The following is a description of a gene set: Genes up-regulated in BCL6 low follicular helper T cells versus T conv cells. Human Gene Set: GSE24574_BCL6_LOW_TFH_VS_TCONV_CD4_TCELL_UP from publication Kitano M, Moriyama S, Ando Y, Hikida M, Mori Y, Kurosaki T, Okada T (PMID 21636294) We found that a number of Tfh cells downmodulated BCL6 protein after their development, and we sought to compare the gene expression between BCL6-hi Tfh cells and BCL6-low Tfh cells. species: Homo sapiens, and this is the list of marker genes: USP9Y, SPPL2B, PDHA2, BNIP1, ZNF200, CASP2, WNT11, OTUD3, TOR1B, PER1, PAX4, TBPL1, SGSM3, KCNF1, SUMO4, KALRN, VTN, AGT, SOCS5, ALDH1L1, LMF2, FOXD1, ADRA2A (adrenoceptor alpha 2A), ZNF140, ASXL1 (NCBI Gene Id 23393), PNPLA2, GIP, HAVCR1, ACVRL1, RBM5, GRIK5 (glutamate ionotropic receptor kainate type subunit 5), CHL1, ARHGAP44, GCSH, ABCB8, ARHGEF17, H3C4, KLK2, TNK1, XAF1, JADE3, ABCB9, KCNJ8, POM121L6P, GTF2H2, RAP1GAP, SYNPO, PDE4C, UPK1B, MATN4, ATP6V0C, SLC16A4, ITGAV, HS2ST1, PEG3, TEC (tec protein tyrosine kinase), TBP, GABRA3, DCK, CRHR1, PPOX, SLC5A2, TMPRSS2, RBM4B, ZNF217, MAPK10, SLCO3A1, BMP6, BRME1, TTK, CTSZ, SND1-IT1, NBN, VCAN (versican), GPD1L, CX3CR1, TENM4, BCL2L1, TLR3, PC, MUC1, CKB (creatine kinase B), ENSG00000291006, HTR2C, TLR6, ATP6V1G2, ANXA2P1, SLC31A2, AIPL1, XRCC4, CEP43, FOXO4, PHKA1, PF4V1, FCHSD2, PCCB, NSD2, LMO1, IFNAR1 (NCBI Gene Id 3454), FRMPD1, PUDP, TPD52, RNF8, ARHGEF15, HOXB7, UNC13A, FPR1, EDIL3, RAD51D, IL1RN, PLK2 (NCBI Gene Id 10769), PLS1, CLDN7, USP24, P2RX7, DCC, TRIM52, WNT8B (Wnt family member 8B), RHOD, RPP30, SUN1, C17orf75, CEMIP, PAIP2B, HADH, YTHDC2, SEMA6C, FCGR3B, SPN, ACHE, USO1, BTBD2, POP7, MEST, LMO7, COLGALT2, CACNB2, PROX1, LIF, SEC23B, DSTYK, C15orf39, ARHGEF10, CCDC9, IFNA8, ASTN2, WWOX, POLE2, ECPAS, GRIA1, CDK2, GNG11, REM1, NR1H4 (NCBI Gene Id 9971), GJB1, ALDOB, SLC5A4, H2BC7, MAGEB2, CCNE2, KLRB1, GPR31, PNPLA4, LMOD1, TRAF6, FOXM1, ATP6V0A1, RPL4, PTPN13, SCD (NCBI Gene Id 6319), BTN2A1, FBXO9, TMEM158, VILL, PNLIPRP2, PRCC, IL16, NFKBIL1, PTGER2, IL12A, BMPR1A, COG2, LIPE, PCDHGB4, SNRPB2, CRLF3, UGT2B4, CA5BP1, RNASE4, GAS1, OCEL1, KDELR3, TWIST1, EFR3B